Given this list of marker genes COL22A1, CTSG, COL5A3, S100A6, F9, COL11A1, CST3, COL2A1, S100A11, S100A13, THBS1, here is a description of the gene set: Human Gene Set: HEBERT_MATRISOME_TNBC_BONE_METASTASIS Matrisome proteins found in significantly higher abundance in TNBC bone metastasis niche compared to TNBC brain, liver and lung metastatic niches. from publication Hebert JD, Myers SA, Naba A, Abbruzzese G, Lamar JM, Carr SA, Hynes RO (PMID 32019869) species: Homo sapiens We have previously developed methods for enriching tissue samples for their ECM protein content by taking advantage of the relative insolubility of the ECM, and we have used these techniques in conjunction with mass spectrometry-based proteomics to profile the matrisome, the complete collection of both core ECM and ECM-associated proteins, in several different cancers. Here we define and compare the ECM components of metastatic niches and how they differ among the specific secondary sites common in TNBC. For this purpose, we use as a model the MDA-MB-231 human TNBC cell line, originally derived from a patient pleural effusion (24), which is capable of metastasizing to the brain, lungs, liver and bone marrow in mouse xenografts. We identify which ECM proteins are commonly elevated at multiple different metastatic sites, and which are preferentially elevated in particular sites. We investigate how these specific ECM proteins, as well as the tumor matrix overall, are differentially produced by the tumor and stromal cells; in this paper, we use stromal to include all cells in the tumor that are not tumor cells. These comparisons did not simply identify the most elevated proteins in each tissue, but rather the proteins most significantly different in abundance in one tissue relative to all others. Separate analyses were conducted for tumor-cell-derived (human) and stroma-derived (mouse) proteins. In this study, we performed an unbiased, quantitative mass spectrometric survey of ECM proteins present in MDA-MB-231 breast cancer xenograft metastases to the brain, lungs, liver and bone marrow. This gene set lists the matrisome proteins found in significantly higher abundance in TNBC bone metastasis niche compared to TNBC brain, liver and lung metastatic niches.